The following is a description of a gene set: Human Gene Set: REACTOME_NUCLEOTIDE_BINDING_DOMAIN_LEUCINE_RICH_REPEAT_CONTAINING_RECEPTOR_NLR_SIGNALING_PATHWAYS Nucleotide-binding domain, leucine rich repeat containing receptor (NLR) signaling pathways species: Homo sapiens, and this is the list of marker genes: NLRP3, NOD2 (nucleotide binding oligomerization domain containing 2), CASP4, IKBKG, BCL2L1, MEFV, UBA52, CHUK, NLRP1, TAB1, MAP3K7, MAPK11, RELA, PSTPIP1, AIM2, TNFAIP3 (TNF alpha induced protein 3), BIRC2, CASP9, RPS27A, MAPK14, MAPK12, APP, MAPK13, UBC, UBE2N, CYLD, TAB2, HSP90AB1, NFKB2, TAB3, ITCH, NOD1, TXN, PYCARD, UBE2V1, TRAF6, IRAK1, RIPK2, BIRC3, P2RX7, MAP2K6, IKBKB (inhibitor of nuclear factor kappa B kinase subunit beta), SUGT1, NLRC4 (NLR family CARD domain containing 4), BCL2 (BCL2 apoptosis regulator), PANX1, CASP8, IRAK2, AAMP, UBB, CASP2, CARD9, HMOX1, NFKB1, CASP1, TXNIP